Given this list of marker genes Mapk3, Braf, Ccnd1 (cyclin D1), Mdm2, Kras, Junb, Jun, Rb1, Arf1, Cdkn2a, Nras, Raf1, Map2k2, Ets1, Mapk1, Hras, Araf, Fos, Rras, Dmp1, Myc, Ets2, Map2k1, Trp53, E2f1, here is a description of the gene set: Mouse Gene Set: WP_NOVEL_JUNDMP1_PATHWAY studied in species Mus musculus Novel Jun-Dmp1 pathway